The following is a description of a gene set: from publication Chen Y, Wang X (PMID 31504780) Genes predicted to be targets of miRBase v22 microRNA mmu_miR_6957_5p in miRDB v6.0 with MirTarget v4 prediction scores > 80 (high confidence targets). species: Mus musculus Mouse Gene Set: MIR_6957_5P, and this is the list of marker genes: Sptbn2, Ptafr, Nanos2, Snap23, Mecp2, Msx2, Stum, Vps26b, Siglecl2, Dtd1, Fads1, Cadm2, Tfdp2, Syt1, Rreb1, Mettl25b, Sec22c, Fam98a, Cdhr1, Man1a, Pomk, Traf3, Kdm5a (NCBI Gene Id 94042), Nr2e1, Cdr2l, Rfx3, Kcnq3, Specc1, Psat1, Dennd4a, Bcor, Tram1, Fbxo39, H2-Aa, Vat1l (vesicle amine transport protein 1 like), Sult1d1, Zfp58, Dcx, Tram2, Fitm2, Kcnj6, Phf21a, Rgcc, Nfat5, Neb, Phlpp2, Neurod1, Foxn2, Med18, Zfp870, Gtf3c4, Vps50, Sox11, Nup155, Psd3, Or10h5, Pdk4, Pip4k2c, Grhl3, Ipmk, Rbm4b, Ift81, Epha5, Eea1, Fgf9, Uggt1, Slfn14, Lims1, CK137956, Cacng6, Trib2, Snu13, Apln, Grpel1, Cbl, Dgkk, Trim67, Dnajc16, Rtl4, Ednrb (NCBI Gene Id 13618), Otub1, Adgrl4, Atp2c1, Ube2ql1, Kdelr1, Sos1, Ceacam20, Atxn1l (NCBI Gene Id 78838), Cct3, Sbk3, Acp2, Cds1, 4933411K16Rik, Ppp1r1c, Gjc3, Usp37, Bdh2, Il22ra1, Gcnt2, Or2t48 (olfactory receptor family 2 subfamily T member 48, NCBI Gene Id 258879), Rsbn1 (rosbin, round spermatid basic protein 1), Zfp735, Dnajc3, Usp17la, Slamf6, Tmem154, Dnajc14, Kcnma1, Stard4, Dapk1, Lcorl, Pcdh17, Cept1, Kpna1, Hnrnpr, Cdk19, Tfap2a, Rlig1, Prom1, Map9, Trappc3, Slk, Prr16, Ppp2r5c, Tnfsf12, D5Ertd579e, Cav1, Rad54l2, Fbxl7, Slc6a11, Scfd2, Golga7, Kprp, Abcg8, Phlpp1, Srpra, Tbr1, Pcdh15, Rc3h2, Cyp4a12a (NCBI Gene Id 277753), Fgf12, Carmil1, Cpne8, Zfp384, Frmpd3, Ube2q1 (ubiquitin-conjugating enzyme E2Q family member 1), Ccny, Vopp1, Trappc2b, Gpc6, Dusp10, R3hdm2, Rasgrf1, Kel, Cybc1, Aff4, Klhl31, Tmem47, Gpr174, E2f8, Dnah9, Piezo2, Mrpl27, Rin2, Mylk4, Pbx1, Nrxn2, Marchf2, Kctd14, Ptprk